Given this list of marker genes PRKACB, LYN, CREBBP, PRKACA, PAK2, RAF1, PAK3, EP300, ICAM3, RPS6KA5, PAK1, FYN, RELB, CD209, NFKB1, PRKACG, KRAS, HRAS (HRas proto-oncogene, GTPase), RELA, NRAS, ICAM2, here is a description of the gene set: CD209 (DC-SIGN) signaling species: Homo sapiens Human Gene Set: REACTOME_CD209_DC_SIGN_SIGNALING